The following is a description of a gene set: Strongly up-regulated at 2 h during differentiation of 3T3-L1 cells (fibroblast) into adipocytes. Mouse Gene Set: BURTON_ADIPOGENESIS_1 species: Mus musculus During cellular differentiation and development, it is recognized that many complex molecular mechanisms as well as precise patterns of differentially expressed genes occur in directing precursor cells toward a given lineage. Using microarray-based technology, we examined gene expression across the course of 3T3-L1 adipocyte differentiation. Total cellular RNA was isolated at times 0, 2, 8, 16, 24, 48, and 96 h following treatment with either standard hormonal inducers of differentiation; insulin, dexamethasone, isobutylmethylxanthine (IDX), or IDX plus trichostatin A (TsA), a histone deacetylase inhibitor and potent adipogenic inhibitor. cRNA was synthesized from cellular RNA and hybridized to high density Affymetrix MG_U74Av2 microarray gene chips containing 12,488 cDNA/Expressed Sequence Tags (ESTs) probe sets. From the IDX-only treated cells, all probe sets that were either unchanged or differentially expressed less than 2-fold throughout differentiation with respect to time 0 preadipocytes were excluded from further analyses. This selection resulted in a net of 1686 transcripts, 859 were increased in expression, and 827 were decreased in expression at least 2-fold across differentiation. To focus in on genes that were more specific to differentiation, the same analysis was performed on IDX plus TsA-treated non-differentiating cells and all probe sets from the IDX-only group that exhibited similar expression profiles in the non-differentiating TsA-treated group were excluded leaving a total of 1016 transcripts that were regulated only under differentiating conditions. Six hundred and thirty-six of these transcripts were elevated at least 2-fold and 380 exhibited a decrease in expression relative to time 0 preadipocytes. This group of genes was further analyzed using hierarchical clustering and self-organizing maps and resulted in the identification of numerous genes not previously known to be regulated during adipocyte differentiation. Many of these genes may well represent novel adipogenic mediators and markers of adipogenesis. from publication Burton GR, Nagarajan R, Peterson CA, McGehee RE Jr (PMID 15033539), and this is the list of marker genes: Vegfa, Unc45a, Foxc2, Fosl2, Bag3, Errfi1, Dlx2, Arl4c, Litaf, Slc25a25, Irs2, Tsc22d1, Ell2, Dusp2, Nfil3, Ets2, Per1, Sgk1, Nr4a2, Rhob, Dnajb4, Ccn2, Id3, Maff, Cebpb, Il6, Wee1, Thbd, Phlda1, Ctla2b, Cebpd, Ier3